The following is a description of a gene set: species: Homo sapiens Human Gene Set: JAZAG_TGFB1_SIGNALING_DN from publication Jazag A, Ijichi H, Kanai F, Imamura T, Guleng B, Ohta M, Imamura J, Tanaka Y, Tateishi K, Ikenoue T, Kawakami T, Arakawa Y, Miyagishi M, Taira K, Kawabe T, Omata M (PMID 15592526) Genes down-regulated in PANC-1-puro cells (pancreatic cancer) stimulated by TGF1B for 2 h. The transforming growth factor-beta (TGF-beta)-Smad signaling pathway inhibits the growth of human epithelial cells and plays a role in tumor suppression. The Smad4 gene is mutated or deleted in 50% of pancreatic cancers. In this study, we succeeded in establishing Smad4 knockdown (S4KD) pancreatic cancer cell lines using the stable RNA interference (RNAi) method. Smad4 protein expression was reduced dramatically and TGF-beta-Smad signaling was markedly inhibited in the S4KD cell lines. The S4KD and control cells were stimulated with TGF-beta and analysed using a cDNA microarray that contained genes, in order to screen for target molecules downstream of TGF-beta. The microarray analysis revealed that 187 S4KD genes and genes in the control cells were regulated immediately upon TGF-beta stimulation. Quantitative RT-PCR analysis on several of these genes produced results that corroborated the outcome of the microarray analysis. Most of the genes in the S4KD and control cells identified by the array differed, which suggests signaling pathways that differ according to Smad4 status. Of the identified genes, 246 have not been reported previously as genes that lie downstream of TGF-beta. Genes that are involved in cell proliferation, adhesion, and motility were found to be regulated differentially with respect to S4KD and control cells. Cell migration induced by TGF-beta was inhibited in the S4KD cells, which might be associated with a different regulation of integrin beta7. The knock down of a specific gene using stable RNAi appears to be a promising tool for analysing endogenous gene function., and this is the list of marker genes: OAZ3, ABO, H2AC13, ARID3B, USP25, STOML2, MYL11, LSR, SERPINF2, CCL27, ATP2B2, NAA80, TOP2A, ZBTB14, GLRX2, RNH1, EEF1A1, P2RX6, SUFU, FGF6, SAP18, PSMC3, CD244, CSDE1, KCNMB1, PCGF2, GHRL, SIGMAR1, CWC27, FLRT1, PLA1A, NAB2, CLCN7, PCF11, C5